The following is a description of a gene set: Human Gene Set: MIR4790_3P from publication Chen Y, Wang X (PMID 31504780) studied in species Homo sapiens Genes predicted to be targets of miRBase v22 microRNA hsa-miR-4790-3p in miRDB v6.0 with MirTarget v4 prediction scores > 80 (high confidence targets)., and this is the list of marker genes: GRP, SH3RF3, SLC35F1, ARFGEF2, EBF2, VPS37B, TEX55, MAP9, ARL5B, CFLAR, MAP1A, RBFOX3, AJUBA, TOX3, ATRX, NLRP14, PPP2R5A, PDS5A, NETO1, KCNA3, HIKESHI, SERPINI2, ABCD2, DPYD, UBL3, RB1, STEAP2, PMP22, ADH1C, VPS37A, ULK2, SUCLA2, STARD3NL, YBX3 (NCBI Gene Id 8531), ERAP1, ADCY10, MED26, SERBP1, CEMIP, ENC1, FAXC, ABI1, NAGS, AIDA, MCCC2, COMMD3, GSG1L, AGPAT4, MYOM1, NDUFA12, MTCL3, RBM27, NRIP1, MAMLD1, ATAD2B, REL, RCHY1, TRAF2, CEP63, LHFPL3, TMED10, PPFIBP1, PATZ1, WNK1, SRI, FOXR2, ZNF124, C1orf21, FMO5, PROS1, SLMAP, WDR43, CNOT6, CHDH (NCBI Gene Id 55349), FCHSD2, WDR26, TMEM138, MEX3C, CNOT6L, PSAT1, SOWAHC, PKP2, RERE, CAPN6, XKRX, WIPF1 (WAS/WASL interacting protein family member 1)